The following is a description of a gene set: Human Gene Set: HP_VASCULAR_TORTUOSITY Abnormal twisting of arteries or veins. Vascular tortuosity studied in species Homo sapiens, and this is the list of marker genes: NEK1, TGFBR2, SMAD3, EFEMP2, SLC2A10, MT-ATP6, TGFB3, MT-ND4L (NCBI Gene Id 4539), SMAD2 (NCBI Gene Id 654050), MT-ND2, ESAM, FBLN5, MT-CO3, TGFB2, COL5A1 (collagen type V alpha 1 chain), TGFBR1, MT-ND6, MT-ND4, PYCR1, PCGF2, ALDH18A1, NT5E, SELENOI, IPO8, RASA1, ATP7A, MT-CYB, RNU4-2, IDH1, DNAJC30, MT-ND1, APP, MT-ND5